Given this list of marker genes Tomm20l, Sec63, Slc15a4, Tomm20, Timm17b, Timm23, Tomm40, Timm22, Pex14, Sec61a2, Pex13, Sidt2, Sec61a1 (NCBI Gene Id 53976), Tomm40l, Hnrnpa3, Tomm70a, Sidt1, Tmed10, Bloc1s3, Slc15a3, Abca1, Bcs1l, Tomm22, Abcc5, Timm17a, Tmed10-ps, Sec61g, here is a description of the gene set: Mouse Gene Set: GOMF_MACROMOLECULE_TRANSMEMBRANE_TRANSPORTER_ACTIVITY Enables the transfer of a macromolecule from one side of a membrane to the other. species: Mus musculus